The following is a description of a gene set: We combined large-scale mRNA expression analysis and gene mapping to identify genes and loci that control hematopoietic stem cell (HSC) function. We measured mRNA expression levels in purified HSCs isolated from a panel of densely genotyped recombinant inbred mouse strains. We mapped quantitative trait loci (QTLs) associated with variation in expression of thousands of transcripts. By comparing the physical transcript position with the location of the controlling QTL, we identified polymorphic cis-acting stem cell genes. We also identified multiple trans-acting control loci that modify expression of large numbers of genes. These groups of coregulated transcripts identify pathways that specify variation in stem cells. We illustrate this concept with the identification of candidate genes involved with HSC turnover. We compared expression QTLs in HSCs and brain from the same mice and identified both shared and tissue-specific QTLs. Our data are accessible through WebQTL, a web-based interface that allows custom genetic linkage analysis and identification of coregulated transcripts. Genes associated with the same cis-regulatory QTL (quantitative trait loci) in both brain and hematopoietic stem cells (HSC). Human Gene Set: BYSTRYKH_HEMATOPOIESIS_STEM_CELL_AND_BRAIN_QTL_CIS from publication Bystrykh L, Weersing E, Dontje B, Sutton S, Pletcher MT, Wiltshire T, Su AI, Vellenga E, Wang J, Manly KF, Lu L, Chesler EJ, Alberts R, Jansen RC, Williams RW, Cooke MP, de Haan G (PMID 15711547) studied in species Mus musculus, and this is the list of marker genes: MED1, C5orf34, KLC1, NDUFA7, ZNF878, MRPL44, ALAD, SRP9, PTPRF, DAP3, ALDH9A1 (aldehyde dehydrogenase 9 family member A1), NOP10 (NCBI Gene Id 55505), FAM114A2, IFI16, SNHG6, AGTRAP, IQGAP1, ACADL, DDA1, PRDX2, GATAD2A, SARAF, SCOC, CUX1, SNRPB2, ZFP91, SC5D, ARL6IP1, CTSC, RPL26, PRKCE, DPP7, SPG21 (NCBI Gene Id 51324), MRPL35, GLO1, ARHGAP9, HJURP, PSMB6, MTIF2, CLEC16A, MRPS7, GEMIN5, GNB1, HARS1, OCEL1, TRMT1, VPS52, KMT2E, MYO7A, DCTN6, TOX4, ZFAND5, SNORD30, NECAP2, ACAA1, SKP1, ZMYM6, ELOA, PADI2, CPSF2, CCND2 (NCBI Gene Id 894), GFER, TUBGCP4, EEF1AKMT1, USP38, KCNJ9, PDXDC1, THUMPD1